Given this list of marker genes SEC24C, MID1, SCARF2, INTS11, B3GALT6, CENPE, ENPP1, RNF113A, NSUN2, CEP120, IL6ST, TBX1, MED12, SLC4A10, RAB23, GLI3, B3GLCT, KRT5, TRAF7, SMAD6, KANSL1, B4GALT7, FGFR2, WDR35, MASP1, IL11RA (NCBI Gene Id 3590), SLC39A8, KPTN, TCIRG1, RSPRY1, CEP57, TLK2, ERCC2, CEP152, EFNB1, TCOF1, RECQL4, NFIA, ARVCF, JMJD1C, WDR19, ORC1, TRAIP, TMCO1, TBC1D24, MPLKIP, LRP5, GNPTAB, BPNT2, CHST3, H4C9, RNU12, CTSK, WBP4, CYP26B1, CTCF, P4HB, KAT6A, SETD1A, SNX10, TARS1, ADAMTS3, SPECC1L, NSD1, PHEX, PSAT1, PLK4, CCNQ, POLR1A, TWIST1, ALPL, CWC27, APC2, AASS, YY1, PPP3CA, KRT14, ZNF699, KRAS, HUWE1, TGFBR1 (NCBI Gene Id 7046), EBF3, FAT4, DNMT3A, SMO, ESCO2, SON, MAN2B1, ATP6V1B2, GTF2H5, RAC3, MEGF8, GPC6, POR, CDC45, IFT52, ORC6, IPO8, TGFB2, POLA1, DPH1, IRX5, ZIC1, AARS1, SLC35A2, ERF, PRIM1, SLC12A6, OTUD5, FGFR3, ZEB2, ALX4, TGFBR2, B3GAT3, SCUBE3, CCBE1, IFT122, DNA2, DPH2, GMNN, MAF, FGFR1, PPP1CB, RREB1, FLNA, CARS1, HIRA, MSX2, TCF12, CHST14, CDKN1C, PIGT, IFT140, LIG4, RBBP8, DONSON, EIF4A2, EXOC8, NFIX, TGFB3, FLNB, LTBP1, ORC4, UFD1, SEC24D, GP1BB, MYH3, CDH11, STAT3, EXTL3, DSE, COLEC10, SH2B1, MAP3K7, TANC2, AHDC1, KMT2D, COLEC11, CLCN7, SMAD3, SLC2A10, FBN1, TNFSF11, IFT43, AKT1, CHD5, ATRIP, NUP85, KDM6A (NCBI Gene Id 7403), SKI, COMT, PCNT, FBXO11, DPF2, GTF2E2, ERCC3, RTTN, BMP4, DMP1, ATR, SLC25A24, CDT1, CDC6, HNRNPK, SMAD2, PIGO, GLIS3, here is a description of the gene set: Craniosynostosis refers to the premature closure of the cranial sutures. Primary craniosynostosis refers to the closure of one or more sutures due to abnormalities in skull development, and secondary craniosynostosis results from failure of brain growth. Human Gene Set: HP_CRANIOSYNOSTOSIS Craniosynostosis species: Homo sapiens